The following is a description of a gene set: Human Gene Set: GOMF_PROTEIN_DISULFIDE_ISOMERASE_ACTIVITY studied in species Homo sapiens Catalysis of the rearrangement of both intrachain and interchain disulfide bonds in proteins., and this is the list of marker genes: CRELD2, TMX1, P4HB, PDIA5, PDILT, PDIA3, ENOX1, QSOX2, GLRX2, ITGB3, PDIA6, TMX3, QSOX1, ERP27, PDIA4 (protein disulfide isomerase family A member 4), ERP44, PDIA2, ERP29, TXNDC5, CRELD1